Given this list of marker genes Gsta13, Gsta5, Gsta1, Hsd3b1, Hsd3b9, Gsta2, Hsd3b2 (hydroxy-delta-5-steroid dehydrogenase, 3 beta- and steroid delta-isomerase 2), Hsd3b5, Hsd3b8, Ebp (NCBI Gene Id 21660), Hsd3b3, Hsd3b6, Hsd3b4, here is a description of the gene set: species: Mus musculus Catalysis of the reaction: a 3-oxo-delta(5)-steroid = a 3-oxo-delta(4)-steroid. Mouse Gene Set: GOMF_STEROID_DELTA_ISOMERASE_ACTIVITY